The following is a description of a gene set: studied in species Homo sapiens A process in which a calcium ion (Ca2+) is transported from the cytosol into the mitochondrial matrix. Human Gene Set: GOBP_CALCIUM_IMPORT_INTO_THE_MITOCHONDRION, and this is the list of marker genes: AFG3L2, VDAC1, SMDT1, MICU2, MCUR1, MCU, SLC25A23, UCP2 (uncoupling protein 2), MAIP1, PSEN2, MICU1, SPG7 (SPG7 matrix AAA peptidase subunit, paraplegin), MCUB (NCBI Gene Id 55013), MICU3, HSPA9, ITPR1